Given this list of marker genes SERAC1, NDUFS1, ALDOB, KDM6A (lysine demethylase 6A), STAT3, TIMMDC1, APC2, NDUFA11, UQCRC2, PHKG2, HYMAI, PROKR2, GRB10, GJA1, NFS1, GALT, CYC1, GPC4 (glypican 4), BMP6, FUT8, LHX4 (NCBI Gene Id 89884), AGL, PET100, MT-ND1, BBS4, BBS7, KCNJ11, IGF2, MICOS13, MTO1, INS, SCO1 (NCBI Gene Id 6341), NDUFS7, APPL1, CACNA1C, POGZ, YARS1, GHSR, ACADS, ETFA, NUBPL (NUBP iron-sulfur cluster assembly factor, mitochondrial), GATC, UCP2, SUCLG1, NAB2, SCN4A, SECISBP2, BBS5, MT-ND3, MC2R, CAMKMT, POMC, NDUFS2 (NCBI Gene Id 4720), SLC1A1 (solute carrier family 1 member 1), STAR, PLAAT3, HADHB, DGUOK, IL6, MLYCD, NR3C1, PLAG1, NDUFS4, MPV17, AUH, COX10, UQCC3, DLD, PNPO, LRPPRC, FOXRED1, GALK1, TRMT10A, TTC8, NDUFB9, GLI2, CLPB, GFRA1, SLC34A1 (NCBI Gene Id 8561), ZMPSTE24, FGF20, DNAJC19, BCS1L, MRPS28, DYRK1B (NCBI Gene Id 9149), SLC16A1, HSD17B10, GHR, NDUFA1, POLR1A, GYS2, COG8, YY1, SH2B1, SGPL1, SAMD9, MSL3, UQCRH, RNF125, MRPL39, TBX19, HMGCL, SLC52A1, RET, H19, MRPS2, STAT6, ALMS1, ACSL5, ACAD8, NARS2, GATB, TANGO2, KCNQ1, PREPL, SCAPER (NCBI Gene Id 92909), PC, MKS1, NDUFAF8, AKT2, NDUFAF4, KHK, ODC1, PCYT1A, HYOU1, NNT, PRORP, GABRA3, POU1F1, SLC25A36, SLC2A2, HFE (homeostatic iron regulator), EHHADH, NDUFB3, ATP7A, BBIP1, PTEN, DBH, PRKAG2, FOXA2, DIS3L2, TRAPPC11, NPHP1, ETFDH, BBS1, CFAP418, RRAGC, NDUFS6, NDUFAF3, NR1H4, MCCC2, MTOR, IARS2, WRN, DMXL2, NDUFV2, MKKS, KMT2D, SCLT1, PHKA2, G6PC1, COG7, CACNA1S, IFT74, PHKA1, NDUFB10, PROP1, ITGA8, CYB561, HERC1, BBS12, FARSB, ABCC8, INSR, KLF11, MT-ND2, PPP2R5D, PLAGL1, ACAD9, CIC, NEUROD1, HMGCS2, STX5, PGM1, OTC (NCBI Gene Id 5009), BBS9, NFKB2 (nuclear factor kappa B subunit 2), BBS10, WDPCP, CEP19, GREB1L, BLK, HNF4A, SLC3A1, QRSL1, BBS2, SNIP1, TXNRD2, ARL6, DOLK, MMACHC, HTRA2, WNT9B, ALG12, LMNA, EBP, PHKB, POR, ACSF3, CPT2, SDCCAG8, FAH, MPC1, NDUFAF1, PCK1, PIK3R1, CDON, MMAB, WDR11, IGF1, OTX2, PPARG, PAK1 (NCBI Gene Id 5058), ACADSB, ATP5F1D, HADH, LHX3 (NCBI Gene Id 8022), NDUFAF2, AFF4, PCCA, NDUFAF5, WARS2, ARMC5, PTPN22, DDC, KCNJ18, RFX6, GPC3, ENPP1, TFG, ADRA2A, NDUFS3, PPM1B, PLPBP, CYP11A1, GATA6, EIF2S3, HESX1, CYP21A2 (NCBI Gene Id 1589), PPP1R15B, GK, TRPM3, CDKN1C, NDUFB11, FBP1, PDX1, SLC5A2, IFT27, GLYCTK, ACADM, PCCB, CTDP1, GCSH, GATM, TFAM, GH1, ZFP57, ACADVL, NDUFA6, KCNE3, GLUD1, CPT1A, AAAS, MADD, RIMS2, NSD1, NBAS, HMGA2, SLC22A5, ITPR3, ATIC, CEL, COX16 (cytochrome c oxidase assembly factor COX16), TFE3, ACAT1, NDUFAF6, CEP290, SOX3, HRAS, NDUFS8 (NADH:ubiquinone oxidoreductase core subunit S8), LZTFL1, GPR161, PYGL, BCKDHA, ETFB, SLC25A20, MCCC1, GFM2, HSD3B2, TMEM126B, NDUFV1, SLC37A4, COX11, ALDH7A1, PTF1A, PCSK1, MRPS7, GMPPA, TEFM, MMUT, STIM1, PCK2, ASXL2, KCNQ1OT1, HADHA, MEN1, TRIM32, CA5A, MYT1L, IFT172, HNF1A, GCDH, MT-CYB, MRAP, PAX4, ROBO1, UQCRB, GCK, GLI3, IARS1, SHPK, here is a description of the gene set: studied in species Homo sapiens Abnormal blood glucose concentration An abnormality of the concentration of glucose in the blood. Human Gene Set: HP_ABNORMAL_BLOOD_GLUCOSE_CONCENTRATION